The following is a description of a gene set: Mouse Gene Set: WP_PEROXIREDOXIN_2_INDUCED_OVARIAN_FAILURE Peroxiredoxin 2 induced ovarian failure species: Mus musculus, and this is the list of marker genes: Casp3, Hsd3b3, Bax, Star, Cyp11a1, Prdx2, Cycs